Given this list of marker genes APOC3, APP, APOE, APOC2, APOB, here is a description of the gene set: species: Homo sapiens Human Gene Set: GOCC_INTERMEDIATE_DENSITY_LIPOPROTEIN_PARTICLE A triglyceride-rich lipoprotein particle that typically contains APOB100, APOE and APOCs and has a density of 1.006-1.019 g/ml and a diameter of between 25-30 nm. IDL particles are found in blood and are formed by the delipidation of very-low-density lipoprotein particles (VLDL). IDL particles are removed from blood by the liver, following binding to the APOE receptor, or are converted to low-density lipoprotein (LDL).